Given this list of marker genes ALS2, ALDH18A1, NDUFA8 (NADH:ubiquinone oxidoreductase subunit A8), ARSA, GALC, CACNA1S, PRF1, TFG, PNKP, TRAPPC2L, GABRA3, BUB1B, MT-ATP8, MC2R, DPYD, ARX, DOLK, NADK2, AIFM1, CRELD1, PIGA, KCNJ18, ATP5F1E, PAFAH1B1, TXNRD2, RANBP2, NHLRC2, ATP5F1A, MT-ATP6, ATP1A3, ATP5MK, ATPAF2, BCAS3, KRAS, KCNT1, STAR, FGFR1, IFIH1 (NCBI Gene Id 64135), BCAP31, NNT, PRPS1, ATP1A2, MRAP, ATP5F1D, TBCD, here is a description of the gene set: Paralysis of all four limbs, and trunk of the body below the level of an associated injury to the spinal cord. The etiology of quadriplegia is similar to that of paraplegia except that the lesion is in the cervical spinal cord rather than in the thoracic or lumbar segments of the spinal cord. Tetraplegia Human Gene Set: HP_TETRAPLEGIA studied in species Homo sapiens